Given this list of marker genes Cldn5, Pllp, Pten, Sirt2, Cdh1, Mag, Prkci, Myoc (myocilin), Ncmap, Pals1, Jam3, Cd59b, Mal, Pard3, Cldn19, Akr1b1, Cd59a, Pmp22, Anxa2, Marveld2, Mbp, Mpdz, here is a description of the gene set: The portion of the myelin sheath in which layers of cell membrane are tightly juxtaposed, completely excluding cytoplasm. The juxtaposed cytoplasmic surfaces form the major dense line, while the juxtaposed extracellular surfaces form the interperiod line visible in electron micrographs. studied in species Mus musculus Mouse Gene Set: GOCC_COMPACT_MYELIN